Given this list of marker genes SMAD4, FOXO3, SMAD3, BCL2L11, RUNX3, here is a description of the gene set: studied in species Homo sapiens Reactome Pathway: RUNX3 regulates BCL2L11 (BIM) transcription In response to TGF-beta signaling, RUNX3, in cooperation with activated SMADs and FOXO3A, induces transcription of the pro-apoptotic gene BCL2L11 (BIM). part of: Transcriptional regulation by RUNX3